The following is a description of a gene set: Human Gene Set: GOBP_NEGATIVE_REGULATION_OF_RESPONSE_TO_OXIDATIVE_STRESS Any process that stops, prevents or reduces the frequency, rate or extent of response to oxidative stress. studied in species Homo sapiens, and this is the list of marker genes: GGT7, MIR132, RBX1 (NCBI Gene Id 9978), NCOA7, MACROH2A1, ADCYAP1R1, TBC1D24, MCTP1, MEAK7, USP25, OXR1, KEAP1